The following is a description of a gene set: Mouse Gene Set: REACTOME_TERMINAL_PATHWAY_OF_COMPLEMENT studied in species Mus musculus Terminal pathway of complement, and this is the list of marker genes: C8a, C7, C6, C8g, C9, C8b, Hc, Clu